Given this list of marker genes Psmc4, Fzd8, Psmc6, Psmd6, Fzd4, Psmd13, Psma5, Rps27a, Smurf2, Psmb4, Psmd7, Psma1, Psmc2, Psmb7, Psma2, Psmd12, Smurf1, Ubb, Psmc3, Psma4, Dvl2, Fzd2, Fzd7 (NCBI Gene Id 14369), Psmb5, Psma3, Psmb6, Psma6, Psmc5, Psma7 (NCBI Gene Id 26444), Psmc1, Fzd1, Psmd1, here is a description of the gene set: Reactome Pathway: Asymmetric localization of PCP proteins This event has been computationally inferred from an event that has been demonstrated in another species.<p>The inference is based on the homology mapping from PANTHER. Briefly, reactions for which all involved PhysicalEntities (in input, output and catalyst) have a mapped orthologue/paralogue (for complexes at least 75% of components must have a mapping) are inferred to the other species. electronically inferred by orthology from the curated human pathway part of: PCP/CE pathway species: Mus musculus